The following is a description of a gene set: Catalysis of the hydrolysis of internal, alpha-peptide bonds in a polypeptide chain. Mouse Gene Set: GOMF_ENDOPEPTIDASE_ACTIVITY studied in species Mus musculus, and this is the list of marker genes: Adam26b, Pycard, Aph1a, Klk14, Usp33, Ngf, Sval2, Serpina6, Prtn3, Mep1b, Bace1, Mmp21, Cpne1, Klk5, Serpina1d, Thop1, Spink1, Serpinb3d, Htra1, Kng2, Serpinb1c, Serpina3i, Serpina10 (NCBI Gene Id 217847), Htra2, Try5, Tmprss12, Astl, Adam12 (NCBI Gene Id 11489), Psmb6 (proteasome (prosome, macropain) subunit, beta type 6), Prss39, Birc5, Adamts4, Klk6, Gzmb, A2ml1, Prrg3, Gzmk, Itih4, Serpina3f (serine (or cysteine) peptidase inhibitor, clade A, member 3F), Reck, Wfikkn1, Tmprss7, Mmp28, Arrb1, Stfa2, Ctsl, Cst8, Gzme, C1s1, Wfdc11, Wfdc8, Ddi2, Adam30, Ambp, Rhbdf2, Zmpste24, Serpinb1b, Adam32, Usp20, Capn3, Serpina12, Pbp2, Prnp, Rhbdl3, Gpaa1, Mmp7, Spink7, Tpsb2, Tmprss11g, Anxa2, Eppin, Espl1, C3, F12, Psmb3, Naip1, Bace2, Capn5, Serpinb9e, Cstl1, Gzmg, Spock1, Rce1, Adam33, Usp1, Pcsk6, Senp1, Sfrp1, Usp30, Col7a1, Phex, Gapdh-ps15, Cd109, Adam8, Adamts14, Senp6, Corin, Bin1, Tpsg1, Prss1l, Wfikkn2, Lonp1, Prss3, Serping1, Gm7298, Ctsh, Serpina1b, Mst1, C1rl, Proz (protein Z, vitamin K-dependent plasma glycoprotein), Ctrb1 (chymotrypsinogen B1), Usp37, Xiap, C1rb, Adamts18, Serpinb6a, Malt1, Pcsk9, Gbp2b, Adam2, Mmp9, Plat, Habp2, Try10, Sppl3, Adamdec1, Gzmf, Hgf, Prss53 (NCBI Gene Id 330657), Mbtps1, Serpinb9b, Serpinb1a, Cfd, Klk1b21 (NCBI Gene Id 16616), Hc, Prss48, Mmp19, App, Mcpt9, Prss50, Pcsk1n, Cstdc3, Ctsj, Birc6, Spink11, Prss3b, Ctsq, Cstdc6, Serpinf1, Sppl2a, Birc7, Serpina1c, Adamts13, Capn15, Usp9x, Klkb1, Ctla2b, Pgc, Casp14, Gzma, Tmprss2, 1810009J06Rik, Sval3, Snca, Rarres1, F11, Serpinb9d, Capn10, Ltf, Csta2, Usp14, Tmprss6 (transmembrane serine protease 6), Prss33 (serine protease 33), Spint3, Pcsk4, Hp, Prss21, Wfdc12, Casp6, Itih3, Tpsab1, Prss59, Immp2l, Tmprss13, Pcsk1, Nrip2, Ctsb, Ecel1, Tmprss11e, Adam23, Pga5, Adamts17, Afg3l2, Adamts12, Adam4, Ctss, Gapdhrt, Prss8, Aplp2, Cstdc1, Aph1b, Gzmc, Proc, Cts7, Pmpcb, Capn9, Psmb5, Serpina5, Ubac2, Tll1, Mmp16, Spink6, Adam18, Spink2, Capn1, Adamtsl2, Casp8, Tmprss11f, Mmp20, Adam3, Spink10, Wfdc1, Usp48, Spint1, Ctsw, Pappa, Mcpt2, Mmel1, Mansc4, Cst3, Mug1, Eef1ece2, Prss38, Masp1 (NCBI Gene Id 17174), Smr2, Erap1, Cflar, Plg, Mmp1b, Adamts16, Klk1b27, Spink12, Adrm1, St14, Casp7, Ahsg, Adam34l, Ren1, Prepl, Mmp8, Mipep, Capn8, Prss30 (NCBI Gene Id 69196), Serpinb9, Cma1, Serpine2, Papln, Ctsd, Gapdh, Psmd13, Mmp25 (matrix metallopeptidase 25), Ctsg, Prss36, Prss58, Sorl1, Kel, Cts6, Mug2, Cst7, Adam5, Wfdc18, Mmp12, Mmp13, Prss1, Usp11, Elp2, Adamts3, Prss55, Hpn, Serpinb8, Ybey, Adamts7, Adamts1, Csta1, Nln, Atg4b, Casp12, Adamts10, Adam6a, Adam28, Prss42, Cst5, Itih2, Klk1b16, Usp49, Klk4, Casp9, Gzmd, Spint2, Pik3ip1, Tmprss5, Cst9 (NCBI Gene Id 13013), Klk1b4, Tmprss11d, Mcpt4, Wfdc13, Serpini1, Col28a1, Smr2l, Nlrp1b, Lmln, Adam39, C1ra, Cela3a (chymotrypsin-like elastase family, member 3A), Psme1 (proteasome (prosome, macropain) activator subunit 1 (PA28 alpha)), Serpina16, Usp12, F7, Nrip3, Serpinb6e, Mmp17, Serpina3k, Cd46, Mmp23, Cym, Itih5, Serpinb9h, Wfdc5, Ctsr, Stfa3, Col6a3, Rhbdd2, Wfdc10, Serpinb13, Slpi, Serpina3c, Serpinb9f, Wfdc17, Adam7, Tll2, Serpinb3b, Atg4a, Psme3, Tmem59, Lxn, Cela1, Cela3b, Sppl2b (signal peptide peptidase like 2B), Hspd1, Atg4a-ps, Ece1, Prrg4, Htra4, Serpinb6b, Ctsz, Crb2, Sfrp2, Rhbdf1 (rhomboid 5 homolog 1), Csta3, Wfdc6a, Prss22, Elane, Pappa2, Trabd2b, Usp16, Gm2663, Mbtps2, Psmb11, Nlrp3 (NLR family, pyrin domain containing 3), Psmd14, Lgmn, Serpini2, Uchl5, Senp5, Tpp2, Pzp (NCBI Gene Id 11287), Ctrl, Bst2, Acr, Prss27, BC051665, Afg3l1, Adamts5, Adam6b, H13, Tysnd1, Adamts20, Cst12, Ece2, Capn6, Klk1b9, Sval1, Adamts6, Klk1, Ncstn, Cstb, Gm4787, Wfdc3, Gbp5, Tmprss11c, Pigk, Psmb9, Klk1b24, Psen2, Prss56, Asprv1, Serpinb9c, Prss52, Mmp3, Timp4, Clpp, Mep1a, Capns2, Adam34, Psmb8, Prss43, Agt, Adam17, 4930486L24Rik, Serpinb9g, Prss46, Prrg2, Apeh, Itih1, Ctsk, Gapdhrt2, Klk1b3, Klk1b8, Serpinh1, Nrdc, Casp4, Pidd1, Prss35, Mmp14, Ctrc, Adam1b, Klk1b1, Klk15, Wfdc15b, Serpinc1, Ctsll3, Klk10, Serpinb6c, Ace2, Cntnap5a, Htra3, Wfdc15a, Wfdc2, Pcsk5, Serpina3j, Adam1a, Cstdc5, Hrg, Atg4d, Adamts15, Serpinb3a, Gzmn, Tfpi2, Pip, Aim2, Prss40, Ctso, Tmprss15, Dpp4, Serpinb12, Jmjd7, Vsir, Serpina7, Klk7, Senp7, Capn12, A2m, Spink13, Serpina3g, Wfdc16, Serpind1, Prss41, F2, Try4, Cfb, Serpina3a, Senp2, Klk1b5, Prss28, Mme, Adam9 (NCBI Gene Id 11502), Adamts9, Uqcrc2, F3, Blmh, Adam26a, Serpinf2, Timp2, Ctsf, Sva (NCBI Gene Id 20939), Sec11c, Psmf1, Ctsm, Spg7 (SPG7, paraplegin matrix AAA peptidase subunit), Rock2, Pmpca, Spint4, Adam22, Atp23, Adrm1b, Rhbdl1, Tpp1, Usp27x, Adgb, Prss54, Psmb10, Tmprss9, Serpine1, Ndel1 (nudE neurodevelopment protein 1 like 1), Hgfac, Rhbdd1, Klk8, Prss45, Cstdc4, Serpinb3c, Mmp2, Timm50 (translocase of inner mitochondrial membrane 50), Fetub, Yme1l1, Psen1, Casp1, Wfdc6b, Ngp, Capn13, Bad, Adam11, Klk11, Stfa1, Pcsk7, Ctse, Cfi, Tfpi, Masp2, Adam15, Prss57, Klk13, Serpinb2, Nlrc4, Tmprss3, Serpina3b, C1s2, Lonp2, Cps1, Parl, Cast, Serpina9, Prss51, Prss29, Nlrp1a, Bmp1, Oma1, Cela2a, Crim1, Serpinb6d, Psenen, Adam20, Cirop, Klk1b11, Klk1b26, Cst13, Uchl1, Wfdc21, Casp3, Adam10, Atg4c, Adam21, Ace (angiotensin I converting enzyme), Wfdc9, Plau, Mmp15, Gbp2, Serpinb7, Casp2, Usp7, Klk1b22, Capn11, Mcpt8, Adam29, Thbs1, Usp10, Serpinb10, Serpina3m, Aph1c, Psme2, Mmp24, Mcpt1, Psmb7, Prrg1, Cma2, Pttg1, C2, Serpine3, Serpina11, Prss34, Abca2, Tmprss11b, Timp3, Spink5, Usp34, Kng1, Ctsc, Sprtn, Spink4 (serine peptidase inhibitor, Kazal type 4), Klk12, Mmp1a, Stfa2l1, Tasp1, Cts8, Prss23, Immp1l, Prss44, Cts3, Rhbdl2, Adamts19, Gzmm, Adam24, F9, Serpinb11, Kdm8, Usp13, Adam25, Ide, Serpina3n, Prss3l, Wap, Adam19, Furin, Spock3, Sec11a, Capns1, Pebp1, Cst11, Prss37, Serpina1a (serine (or cysteine) peptidase inhibitor, clade A, member 1A, NCBI Gene Id 544889), Usp15 (NCBI Gene Id 70921), Prss2, C4b (NCBI Gene Id 12268), Ovch2, Tmprss4, Serpinb5, Pitrm1, Mmp11, Prep, Mmp27, Serpina1f, Pcsk2, Sppl2c, F10, Mmp10, Prss32, Prss12, Smr3a, Ddi1, Adamts8, Fap (fibroblast activation protein), Rhbdd3, Spink8, Nlrp2, Csn2, Usp29, Klk9, Capn2, Serpina1e, Timp1, Capn7, Adamts2, Tmprss11a, Napsa